The following is a description of a gene set: The aim of this study was to employ a systems-level analysis to elucidate gene expression networks operating in the CD4 T-cell responses which underpin human atopic disease. Genes up-regulated in CD4 T cells from atopic patients: resting versus stimulated with allergen (house dust mite). from publication Bosco A, McKenna KL, Firth MJ, Sly PD, Holt PG (PMID 19414752) studied in species Homo sapiens Human Gene Set: GSE14908_RESTING_VS_HDM_STIM_CD4_TCELL_ATOPIC_PATIENT_UP, and this is the list of marker genes: EEF1B2, THUMPD1, NIT1, PMPCB, UBE2O, DUSP19, SEPTIN10, RPL7A, CYB5R1, CALHM2, ABCB8, CAPRIN1, TRAPPC4, TAF6L, WRAP73, RIDA, ATF6, SPRED1, CDK2, HSP90AB1, NLGN2, AHI1, SMIM11, FBXW11, HDAC1, MAIP1, HS6ST3, ZMAT3 (NCBI Gene Id 64393), MRPS34, MAP1B, RNF11 (ring finger protein 11), FBXL6, H2AZ1, GTF3A, PSMA1, EIF4A1, IMP4, CCNC, PKMYT1, PELO, RWDD2B, MTG2, WDR43, DPP8, ZNF566, SLC7A5, RAB27A, NR2F6, HSBP1, TMEM158, UTP3, TCOF1, CCDC90B (coiled-coil domain containing 90B), POLB, SLC25A22, DEF8, NAA35, DECR1, CALU, CHAC2, CHST4, RBBP7, SH3RF1, EMC8, RGS19, DPP3, ANXA4 (annexin A4), PFDN1, C15orf40 (NCBI Gene Id 123207), MBD3, WIZ, FIBIN, UFC1, VAPA, LMNB1, XRCC1, ATP10A, SOX12, HMGN3, BLMH, EMC7, PRKAG2, RITA1, TRAPPC13, TMEM199, BBLN, CEP89, NUP88, STAU2, CLASP1, PIMREG, MBNL3, TXNDC5, CCDC43, MFSD1 (major facilitator superfamily domain containing 1), TXNDC17, R3HCC1, ARL1, LGALSL, CYP3A7, SACS, COMMD2, FDPS, BAG1, TAF10, EBPL, PBDC1, SEPTIN2, RAX, SLC25A47, SLC31A1, NUP188, HDLBP, CHMP5, ADPRH, GNL2, MDK, GALK2, NME7, THNSL1, DEK, ASPH (NCBI Gene Id 56921), PPAN, NUCB2, CCDC107, GNPTAB, SEM1, ECPAS, SCAF4, BMS1, GLMN, ACO1, RNF121, FEM1B, NDFIP1, JKAMP, SLC4A1AP, SREK1IP1, DDB1, MPP7, KIFAP3, SPOUT1, TSEN34, HIVEP3, FKBP1A, CA5B, DNAJC18, HSPA8, MED28, DMAP1, WDR5, CCNH, CIBAR1, SUV39H1, C2orf76, ALDH9A1, TMEM183A, ZBTB14 (zinc finger and BTB domain containing 14), MGME1, FAR1, N4BP3, CHST2, PSMB4, EIF5B, MOCS2, TM2D3, MIS18A, MRPS23, C1S, MASTL, PSMG4, NUDT21, CIP2A, PRPS1, NUP42, TMEM101, RPS2, NSUN5, LANCL2, LTV1, EIF3I, KDELR3, IMP3, TARS1, NUDCD2, EIF2S3, HELQ, ANXA9, KEAP1, CPZ, GLRX2, PEX3, SIX5, NMNAT1, TNFSF9 (NCBI Gene Id 8744), RRP1, AKR7A2, C11orf24, SSRP1, MFSD10